The following is a description of a gene set: part of: Coagulation pathway The initiation phase of coagulation proceeds through the tissue factor (TF)-mediated generation of a small amount of thrombin on the plasma membrane surfaces of TF-bearing cells (e.g., fibroblasts, smooth muscle cells and pericytes). Additionally, activated cells (e.g., polarized macrophages) and apoptotic cells, along with certain cancer cells, release TF-bearing extracellular vesicles (EVs) with procoagulant activity (Hohensinner PJ et al., 2021; reviewed by Hisada Y et al., 2022; Sachetto ATA et al., 2023). TF is predominantly maintained in a cryptic, coagulant-inactive state on the surfaces of resting cells or EVs (Schecter AD et al. 1997; Bach RR 2006; Kothari H et al. 2013; Grover SP & Mackman N 2018). Upon tissue injury or inflammation TF is converted into its procoagulant isoform at the membrane surface. Ca²⁺-dependent exposure of phosphatidylserine (PS), hydrolysis of sphingomyelin (SM) and thiol-disulfide exchange within TF are thought to synergistically contribute to the activation of TF on the outer plasma membrane (Langer F & Ruf W 2014; Ansari SA et al. 2019). Activated TF becomes exposed to circulating blood and the extracellular part of TF binds both the zymogen factor VII (FVII) and its active serine protease form FVIIa with very high affinity and specificity (Vadivel K& Bajaj SP 2012; Prasad R & Sen P 2018). The TF:FVIIa complex initiates the coagulation protease cascade by converting zymogens FIX and FX to active proteases FIXa and FXa, which are involved in the generation of thrombin. <p>Aberrant expression of TF is associated with various coagulopathies. For example, the procoagulant properties of EVs bearing TF may contribute to thrombosis and disseminated intravascular coagulation in pathophysiologic conditions such as cancer, sepsis, and infection. studied in species Homo sapiens Reactome Pathway: Initiation of coagulation cascade, and this is the list of marker genes: HSPG2, GPC5, TFPI, SDC2, GPC4, F2, SDC4, PROS1, SDC3, F5, F3, AGRN, SERPINC1, F7, GPC6, GPC3, F10, GPC1, GPC2, VWF, SDC1, F8, F9